The following is a description of a gene set: Mouse Gene Set: GOMF_ORGANOPHOSPHATE_ESTER_TRANSMEMBRANE_TRANSPORTER_ACTIVITY Enables the transfer of organophosphate esters from one side of a membrane to the other. Organophosphate esters are small organic molecules containing phosphate ester bonds. species: Mus musculus, and this is the list of marker genes: Slc46a2, Abcc4, Slc25a25, Panx1, Slc35b1, Slc25a4, Slc25a17, Ank, Slc35e3, Abcc5, Slc25a36, Slc25a41, Slc35d1, Slc25a53, Slc35b2, Slc25a47, Slc25a32, Slc37a2, Mfsd2a, Slc35a3, Lrrc8a, Slc35a1, Slc25a31, Slc25a19, Slc33a1, Slc37a4, Slc25a23, Slc44a4, Slc25a5 (solute carrier family 25 (mitochondrial carrier, adenine nucleotide translocator), member 5), Slc35a5, Slc25a42, Atp2a1, Abcd1, Slc25a51, Slc25a24, Slc25a33, Slc25a16, Slc35b4 (solute carrier family 35, member B4), Slc35c1, Tmem241, Slc37a1, Slc35a2, Slc35b3, Slc35d2, Abcd2, Slc25a54, Slc19a1, Slc17a9, Slc35d3